The following is a description of a gene set: species: Mus musculus The reorganization or renovation of existing blood vessels. Mouse Gene Set: GOBP_BLOOD_VESSEL_REMODELING, and this is the list of marker genes: Tgfbr3, Itga4, Gja1, Bcr, Dll4, Angpt2, Lrp1, Tmbim1, Bmpr2, Acvr2b, Fgf8, Atg5, Ednra, Npr2, Igf1, Cbs, Foxc2, Ndp, Tbx1, Ceacam1, Jag1, Nos3, Mdm2, Pbrm1, Atp7a, Tgm2, Adra1b, Ccr2, Nol3, Foxc1, Hrg, Dbh, Chd7, Nos2, Rspo3, Cts8, Nfatc3, Axl, Ext1, Epas1, Eln, Cst3, Ahr, Sema3c, Flt4, Il18 (NCBI Gene Id 16173), Nppc, Hoxa3, Vegfa, Mef2c (NCBI Gene Id 71350), Tgfb2, Crb1, Rbpj, Bax, Acvrl1, Fgf10, Flna, Bak1, Abr, Npr3, Lif